The following is a description of a gene set: Mouse Gene Set: GOBP_FC_RECEPTOR_SIGNALING_PATHWAY studied in species Mus musculus The series of molecular signals initiated by the binding of the Fc portion of an immunoglobulin to an Fc receptor on the surface of a target cell, and ending with the regulation of a downstream cellular process, e.g. transcription. The Fc portion of an immunoglobulin is its C-terminal constant region., and this is the list of marker genes: Fer, Oscar, Nos2, Fcer2a, Fcmr, Myo1g, Fcgr1, Kit, Clec4d, Pigr, Appl1, Appl2, Lck, Fcer1a, Fcgr3, Fcer1g, Cd247, Clec4e, Fcgr4, Nr4a3